Given this list of marker genes LCAT, LIPA, A2M, PRKACG, P4HB, MBTPS2, NCEH1, APOC2, LPA, LIPG (lipase G, endothelial type), APOF, CLTC, RPS27A, PLTP, FGF21, ANGPTL3, UBA52 (ubiquitin A-52 residue ribosomal protein fusion product 1), LMF1, PRKACA, SOAT1, APOA2 (NCBI Gene Id 336), MTTP, CLTA, APOA5, LSR, BMP1, CREB3L3 (NCBI Gene Id 84699), UBB, AP2A1, APOC3, MBTPS1, HDLBP, PRKACB, ABCA1, VLDLR, NPC1, AP2M1, CIDEC, LDLR, AP2B1, UBC, ABCG1, SOAT2, PCSK9, ANGPTL4, APOA4, CUBN, AP2S1, LPL, ZDHHC8, SAR1B, APOA1, MYLIP, APOE, FURIN, APOC1, PCSK6, NR1H3, CETP, GPIHBP1, APOBR, LDLRAP1, AMN, LMF2, ALB, APOC4, LIPC, CES3, APOB, SCARB1, AP2A2, NR1H2, NPC2, PCSK5, ANGPTL8, here is a description of the gene set: Human Gene Set: REACTOME_PLASMA_LIPOPROTEIN_ASSEMBLY_REMODELING_AND_CLEARANCE Plasma lipoprotein assembly, remodeling, and clearance species: Homo sapiens